The following is a description of a gene set: RNA localization is important for the establishment and maintenance of polarity in multiple cell types. Localized RNAs are usually transported along microtubules or actin filaments and become anchored at their destination to some underlying subcellular structure. Retention commonly involves actin or actin-associated proteins, although cytokeratin filaments and dynein anchor certain RNAs. RNA localization is important for diverse processes ranging from cell fate determination to synaptic plasticity; however, so far there have been few comprehensive studies of localized RNAs in mammalian cells. Here we have addressed this issue, focusing on migrating fibroblasts that polarize to form a leading edge and a tail in a process that involves asymmetric distribution of RNAs. We used a fractionation scheme combined with microarrays to identify, on a genome-wide scale, RNAs that localize in protruding pseudopodia of mouse fibroblasts in response to migratory stimuli. We find that a diverse group of RNAs accumulates in such pseudopodial protrusions. Through their 3' untranslated regions these transcripts are anchored in granules concentrated at the plus ends of detyrosinated microtubules. RNAs in the granules associate with the adenomatous polyposis coli (APC) tumour suppressor and the fragile X mental retardation protein (FMRP). APC is required for the accumulation of transcripts in protrusions. Our results suggest a new type of RNA anchoring mechanism as well as a new, unanticipated function for APC in localizing RNAs. studied in species Mus musculus from publication Mili S, Moissoglu K, Macara IG (PMID 18451862) Human Gene Set: MILI_PSEUDOPODIA_CHEMOTAXIS_DN Transcripts depleted in pseudopodia of NIH/3T3 cells (fibroblast) in response to the chemotactic migration stimulus by lysophosphatidic acid (LPA)., and this is the list of marker genes: SIGMAR1, SCFD1, P4HA2, ABCC10 (ATP binding cassette subfamily C member 10), RNPS1, SPNS1, FGFR1 (NCBI Gene Id 84151), ERH, P3H1, VCP (valosin containing protein), TUBGCP4, PLXNB2, PSAP, SLC38A10, SERPINE1 (NCBI Gene Id 5054), PCDH19, B4GAT1, TENM4, LRRC8C, SLC20A1, SRI, DNAAF9, DDR1, GGCX, TXNDC5, PPP6R3, ADRB2, SREBF2, ANKRD11, POGLUT2, ALG1, HMGCS1, ATP1A1, MALAT1, RANBP3, ANGPTL2, NAGA, SUN1, HLA-DMB, CHKA, ATP13A1, MATN2, KDM6B, NFKBIZ, SLC12A4, MPG, NEAT1, MAST4, PNPLA7, TGIF1, ARHGAP17, DIDO1, LIME1, RARA, FIBP, SLC39A7, HMGCR, TM9SF1, NFIB, UBE2I, APLP2, SOD1, TXNIP, FZD7, GMPR2, CALD1, LOX, RACK1, P4HA1, SLC11A2, CLSTN1, POFUT1 (protein O-fucosyltransferase 1), THRAP3 (NCBI Gene Id 9967), FOS, CTSB, NAGK, SNED1, ZDHHC5, GNB1, RPN2, SGMS1, ITGA3, DHRS7, MFSD9, ALKBH1, TLN1, E4F1, ABCC1, FAM53B, KLF3, TTC19, AKR1B10, POR, RPN1, LMBRD1 (LMBR1 domain containing 1), P2RX4, SIRT3, PIM3, ZMIZ1, SLC30A6, GPRC5B, ELOVL1, EIF1, EMILIN1, GLG1, APP, MATN4, SMG5, ACTL6A, HNRNPDL, VASN, SBNO2, EIF2AK3, FLNB, ADAMTS5, SERINC3 (serine incorporator 3), CTNNA1, SLC44A2 (NCBI Gene Id 57368), ZZEF1, TMEM33, CHST12, PPP1R10, PHB2, MPZL1, LAMC1, DDOST, RPL41, SLC39A14, MAPK8IP3 (mitogen-activated protein kinase 8 interacting protein 3), ADNP2, GMCL1, MIR23A, MMP11, HTT, NAGLU, CUX1, HLA-B, EPB41L2, USP7, RNF10, ITPRIP, SLC1A4, FBLN2, C1R, PCDH1, GGNBP2, CTNNB1, MSLN, DAG1, POFUT2, GSPT1, ITGA5, RPS10, RRBP1, TOR1B, UBTF, RPL30, CPSF7, SPTLC1, MFSD10, BRMS1, BMP1, MAN2B1, RUSC2, CD9 (NCBI Gene Id 928), GALNT18, LDLR, MOGS, SNHG3, CLCN4, PUF60, SNRNP48, NPR2, NONO, DEGS1, SLC10A3, SEC61A1, IGF1R, NEU1, BCAP31 (B cell receptor associated protein 31), STT3A, LRP1, PDE7A, SOCS3, HSPA5, ACVR1, SLC19A1, PVR, LY6E, NHLRC3, SLC35A2, NCEH1, CDIP1, SLC23A2, GCN1, SEC61A2 (NCBI Gene Id 88207), STEAP3, DOLK, GPI, KLF6, ACLY, TM9SF2, RBM39, SCD, AXL, GNS, MFSD14B, SOD3, AQP1, DHX30, PIGM, PFKL, KCNN4, WWP2, DGAT1, DGCR2, PTGS1, PLOD1, ABCC5, THBS1, SYVN1, KHK, SEMA3F, FTX (FTX transcript, XIST regulator), SCAMP2, CHPF, PPT1, BCL9, IL6ST, CNNM2, PCNX3, SLC2A10, GSK3B, CHUK, THBS3, SUN2, SFPQ, PLD3, RCN3, PDIA6, POLDIP3, H3-3B, LRP12, C1GALT1C1, TRIM35, SF3B3, ADORA2B, FN1, PLAT, SLC12A9, SNX29, ECM1, NEDD4L, TMEM43 (NCBI Gene Id 79188), CNOT3 (NCBI Gene Id 9756), HSPA8, MFSD11, DCBLD1, MMP14, AP2A2, GPR108, RPAP1, ABCA3, BTG1, PDIA3, CKAP4, SERPINF1, B3GNT2, FADS3 (fatty acid desaturase 3), SLC4A7, SNORD30, SEL1L, FZD2, PDGFRA, SELENOS, TWSG1, CLCF1, TCTN1, PPIL2, SLC2A1, BAIAP2, AKAP1, TMPPE, FUS, SLC38A2 (solute carrier family 38 member 2), TMEM109, RPL12, ESYT1, RGS3, NISCH, COL4A5, CLDN9, PTPRA, TTC7A, PAN3, MED15, FOSB, ZNF266, ATP5IF1, MTCH2, SEMA3B, SCPEP1, FAM171A1, USP53, EDEM2, SFSWAP, SLC7A6, NAA40, BCLAF1, PTPRF, SGPL1, PIK3IP1, PRNP, SFI1, ITGB1, CYBC1, GAA, CHPF2, ESD, RBX1, TYW1, ATAT1, SLCO2A1, VCL, GLA, NRP2, HACD3, ATRN, RPS24, RAB5B, TIMP2, LGMN, RIOK1, PDIA5, DPF2, CYP4F8, GPAA1 (NCBI Gene Id 8733), LTBP4, ZFP36 (NCBI Gene Id 7538), EPHB4 (EPH receptor B4), OGA, TAPBP, KATNBL1, SS18L1, CLIC1, LAMB2, KRIT1, TAP2, PABPN1, ATP10A, SLC19A2, AGFG2, SLC16A1, DIAPH1, ADAMTSL4 (NCBI Gene Id 80075), PKD1, C6orf89, ERO1A, QSOX1, SLC8B1 (NCBI Gene Id 80024), ANXA7, MST1, CLCN6 (chloride voltage-gated channel 6), ABCA7, IGSF3, NOC2L, GRN, BIRC2, SERINC1, CCNT2, SLC35F6, MACO1, PI16, HSD17B12, OGT, PDGFRB, TRA2A, PLXNA3, SLC38A4, ABCA2, FGF7, IGSF8, SLC20A2, RGMB, TPBG, SON, SEMA4C, ACKR3, COLGALT1, SPPL2A, TLR2, PLA2G7, WLS, COL4A6, C1S, ASAP1, SLC29A1, NRP1, ZFYVE27, CDS2, CCNY, DUSP1, NPC1, TNFSF9, KCNQ1OT1, SNX14, COL5A1, ZSWIM8, COL16A1, F3, TM2D3, NDEL1, ARMC9, LHFPL2 (NCBI Gene Id 285713), TRPS1, HSF1, GANAB (glucosidase II alpha subunit), EMC1, SLC6A6, COL4A1 (collagen type IV alpha 1 chain), ABHD12, TIMP3, CD109, POLG, GAS5, CSPG4, TMED7, USP14, AREL1